The following is a description of a gene set: Human Gene Set: GSE23398_WT_VS_IL2_KO_CD4_TCELL_SCURFY_MOUSE_DN from publication Sharma R, Sharma PR, Kim YC, Leitinger N, Lee JK, Fu SM, Ju ST (PMID 21169543) species: Homo sapiens Genes down-regulated in lymph node CD4 T cells: scurfy (non-functional form of FOXP3) versus scurfy and IL2 knockout. The goal of the study was to identify the genes which are regulated by Interleukin-2 in the CD4+ T cells of the scurfy mice during regulatory T-cell deficiency. Scurfy (Sf) mice bear a mutation in the forkhead box P3 (Foxp3) transcription factor, lack regulatory T-cells (Treg), develop multi-organ inflammation, and die prematurely. The major target organs affected are skin, lungs, and liver. Sf mice lacking the Il2 gene (Sf.Il2-/-), despite devoid of Treg, did not develop skin and lung inflammation, but the inflammation in liver, pancreas, submandibular gland and colon remained. Genome-wide microarray analysis revealed hundreds of genes were differentially regulated among Sf, Sf.Il2-/-, and B6 CD4+ T-cells but the most changes were those encoding receptors for trafficking/chemotaxis/retention and lymphokines. Our study suggests that IL-2 controls the skin and lung inflammation in Sf mice in an apparent \organ-specific\ manner through two novel mechanisms: by regulating the expression of genes encoding receptors for T-cell trafficking/chemotaxis/retention and by regulating Th2 cell expansion and lymphokine production. Thus, IL-2 is a master regulator for multi-organ inflammation and an underlying etiological factor for various diseases associated with skin and lung inflammation. Methods: CD4+ T cells were purified by Fluorescence Assisted Cell Sorting from the peripheral lymph nodes of (A) three individual Scurfy (Sf; B6.Cg-Foxp3sf/J) male mice, (B) three individual Sf.Il2-/- male mice (Scurfy mice carrying a null Interleukin (IL)-2 gene (B6.129P2-Il2tm1Hor/J)) and (C) a pooled sample of lymph nodes from two B6 (C57BL/6J) mice. All the mice were 3 weeks old. Total RNA was prepared using RNeasy mini kit (Qiagen). RNA samples were converted to cRNA, labeled and hybridized to Affymetrix Mouse 430_2 chips (Mouse Genome 430 2.0 Array, Affymetrix, Santa Clara, CA) at the University of Virginia DNA Sciences Core Facility., and this is the list of marker genes: NDUFB11, TRIM23, TBCEL, CST11, HERPUD1, ATP1B3, SEMA4C, ZMYM2, RPL4, UFSP2, CAMK1D, ARL15, EIF3M, HNRNPM, GNA15, EMB, FAM118B, FAM151B, SLC38A9, SLC49A4, STING1, RP2, RNF146, AGO4 (argonaute RISC component 4), ZFAND6, DPAGT1, NSA2, CRLS1, RNASE4, OAZ2, MTMR6, MAX, CCDC117, WDR35, ZNF597, PLEKHA1, SURF4, ALOX5AP, KLHL28, FUT11, NTAQ1, YPEL2, RPL7, KLHL6, PDCD4, DNAJC24, ZBTB8A, XBP1, RASAL3, STAT4, TMEM37, FRY, CTU1, CDC73, COX4I1, IFT140, FXR1, PSMB1, KLF13, TRAM1, TP53BP1, ANKRD37, ACBD6, BBS9, HPGD, RPLP0, STX2, TOP2B, ING3, UBXN2B, HSP90B1, SH3BGRL2 (NCBI Gene Id 83699), ACADM, ERGIC2, PRXL2C, YPEL3, SSH2, MT2A, ARHGEF6, RSU1, EEF2K, TBC1D24, ZC4H2, ABCD2, STK38, DYNC1LI2, FARS2, DR1, SNRPB2, RAP1A, CREB3L2, POLD4, HMGCR, SLC30A5, MAGED2, FXYD2, PTRH2, PDCL, IQCB1 (NCBI Gene Id 9657), ZNF12, PDIA6, ZDHHC20 (zinc finger DHHC-type palmitoyltransferase 20), ZNF644, N4BP2L1 (NCBI Gene Id 90634), IVNS1ABP, EIF3K, IFT46, SGSM3, RPS15A, CNOT2, CCNI, ARL5B, ZCCHC14, OSBP, TNFAIP8L2, FAM107B, DIPK1A, HERC4, DHX40, CALCOCO1, ANKRD44, IL16, C1orf21, ST8SIA4, ZC3H6, SNAP23, CXCR4, BTG1, ATG101, SORD, FAR1, MT1E, ATP2C1, CCNY, MMP8, CPVL, RTRAF, PCMTD2, RPAIN, CCL24, RSPH9, QKI, USF1, SLC9A6, ZNF292, DCXR, SSBP2, TBRG1, CERT1, SMIM13, LEPROTL1, TIFAB, EIF3H, PIAS2, LTC4S, RSF1, ARL4C, LAPTM4A, HECA, CHMP5, MIGA1, WAC, STARD7, DHCR24, RPL34, MCTP1, METTL27, PAIP2, RPL13A, COX7A2L, RWDD2A, UBN1, CD163, RPS3A, FBXL20, UFD1 (ubiquitin recognition factor in ER associated degradation 1), KANSL2, LDAF1, BSDC1, ZMYND8, DNAJC5, CCNG2, CIR1, FRAT2, STK24, HNRNPUL1, COMMD10, NCF1, RAB1A, FUNDC1, PLEKHH1, JMY, NAT9, HHEX, ARHGAP15, DEDD2, TCP11L2, RAMP1, RPS9, PDIA3